Given this list of marker genes Rilpl1, Rftn1, Tsc2, Clip1, Rilpl2, Reep2, Cd24a, Arl6, Itgb1, Umod, here is a description of the gene set: Mouse Gene Set: GOBP_PROTEIN_TRANSPORT_WITHIN_LIPID_BILAYER species: Mus musculus The directed movement of a protein from one location to another within a lipid bilayer.